The following is a description of a gene set: Mouse Gene Set: GOBP_POSITIVE_REGULATION_OF_INTERFERON_BETA_PRODUCTION Any process that activates or increases the frequency, rate, or extent of interferon-beta production. species: Mus musculus, and this is the list of marker genes: Arrdc4, Oas3, Tlr9, Tlr2, Polr3d, Hsp90aa1, Ddx3x, Ifnar1, Zc3hav1, Irf1, Irf7, Polr3g, Ptpn11, Oas1c, Ifih1, Tradd, Oas1g, Riok3, Oas1b, Ptpn22, Polr3b, Oas2, Trim65, Tlr7, Irf3, Flot1, Mavs, Rigi, Polr3f, Polr3a, Trim56, Isg15, Tlr3 (NCBI Gene Id 142980), Oas1f, Oas1a, Traf3ip3, Hmgb2, Tbk1, Sting1, Dhx9, Hmgb1, D1Pas1, Oas1h, Rnf135, Tlr4, Ticam1, Polr3c, Zbtb20, Tomm70a, Tlr8, Oas1d, Oas1e